Given this list of marker genes MIR27B, PTPRF, IL10, ADIPOQ, ADAM15 (NCBI Gene Id 8751), MIR148A, here is a description of the gene set: Human Gene Set: GOBP_NEGATIVE_REGULATION_OF_RECEPTOR_BINDING Any process that stops, prevents or reduces the frequency, rate or extent of a protein or other molecule binding to a receptor. species: Homo sapiens